The following is a description of a gene set: Human Gene Set: chr4q33 studied in species Homo sapiens, and this is the list of marker genes: HPF1, LINC02512, SH3RF1, HSP90AA6P, LINC02382, PTGES3P3, CLCN3, APOBEC3AP1, AADAT, LINC01612, RNU6ATAC13P (NCBI Gene Id 106479549), ENSG00000295852, ENSG00000301423, LINC02275, MFAP3L, NEK1 (NCBI Gene Id 51037)